The following is a description of a gene set: The involvement of the c-Myc transcription factor in neoplastic transformation is well documented. However, which of its numerous target genes are crucial for tumorigenesis remains a frequently contested issue. We have recently established a non-transgenic murine model for B-cell lymphoma based on neoplastic conversion of p53-null bone marrow cells by conditionally active Myc. Using this model, we have identified a number of genes whose expression levels are affected by Myc during B-lymphomagenesis. Here we discuss their possible roles in neoplastic processes and describe an experimental approach allowing in vivo validation of these roles. We demonstrate that lymphoma cells overexpressing one of the Myc targets, the interleukin-10 receptor gene, have a very strong selective advantage over low IL10R expressors. Furthermore, Mcl1, a presumptive IL10R effector, also confers selective advantages when overexpressed in Myc-transformed hematopoietic cells. Thus, both IL10R and Mcl1 might be amenable to therapeutic interventions, and new targets can be identified and validated using the selection approach. Genes up-regulated in B cell lymphoma tumors expressing an activated form of MYC. from publication Yu D, Cozma D, Park A, Thomas-Tikhonenko A (PMID 16382050) Mouse Gene Set: YU_MYC_TARGETS_UP studied in species Mus musculus, and this is the list of marker genes: Aurka, Birc5, Cks2, Txn1, Cdk1, Ube2s, Mki67 (NCBI Gene Id 330663), Pcna, Dtl, Anln, Kif20a, Gm15987, Ybx3, Cks1b, Racgap1, Dctpp1, Gsdme, Uchl5, Top2a, Hmgn2, Fdps, Hnrnpll (heterogeneous nuclear ribonucleoprotein L-like), Gmnn, Ect2, Gm4870, Nup54 (NCBI Gene Id 269113), Bub1, Rrm1, Fam136a, Brca2, Ccnb2 (NCBI Gene Id 235460), Cdkn3, Nudcd2, Gm4739, Tfdp1, Plk1, Pclaf, Aspm, Strap, Idi1, E2f8, Tspan4, Kpna2, Clic4